The following is a description of a gene set: Furin is a proprotein convertase induced in activated T cells, reported to processes the anti-inflammatory cytokine TGFb-1. Herein, we show that conditional deletion of furin in T cells allowed for normal T cell development but impaired the function of regulatory T cells and effector cells, which produced less TGFb-1. Furin-deficient Treg cells, were less protective in a T cell transfer colitis model and failed to induce Foxp3 in normal T cells. Furin-deficient effector cells were inherently overly active and were resistant to suppressive activity of wild-type Tregs. Thus, our results indicate that furin is indispensable in maintaining peripheral tolerance, which is due, at least in part, to its nonredundant, essential function in regulating TGFb-1 production. Targeting furin has emerged as a strategy in malignant and infectious disease. The current work suggests that inhibiting furin might activate immune responses, but may result in a breakdown in peripheral tolerance. from publication Pesu M, Watford WT, Wei L, Xu L, Fuss I, Strober W, Andersson J, Shevach EM, Quezado M, Bouladoux N, Roebroek A, Belkaid Y, Creemers J, O'Shea JJ (PMID 18701887) Genes up-regulated in naïve wildtype CD4 T cells versus those from T cell specific FURIN knockout mice. Human Gene Set: GSE11884_WT_VS_FURIN_KO_NAIVE_CD4_TCELL_UP studied in species Homo sapiens, and this is the list of marker genes: PAXX, TM7SF3, FEZF2, GPR153, SRGAP1, RNF186, PDLIM2, MRM3, SNX18, DTHD1, IRF2BP2, PTGDR, RUSC2, KCTD12, TOMM34, LRRC30, CAVIN1, ASPH, PIR, ANKRD34B, RAB4B, MOXD1, SLC7A13, CATSPER1, MIR99B, GHRH, DSCC1, FLRT1, OTOG, SERPINB8, DAZAP2, NCKAP5L, RPS4Y2, SLC25A10, GALR2, SLC6A3 (solute carrier family 6 member 3), UNC45A, MARCHF8, GARNL3, PLIN1, PLCXD2, OMP, SH3PXD2A, DOK3, ZFP90, PM20D1, IFNA2, SHBG, DKKL1, SLCO4C1, HIP1, TBC1D9B, ANXA1, CCL1, SLC31A1, ODAD4, RPN1, PWWP3B, CCN2, PDGFRB, HTR5A, KLHL13, RIMKLA, ACAA2, CCDC107, CYBRD1, NUTM1, TCF7, GRK4, POM121L2, TAGAP, CLCN7, RNF152, TDRD12, MAB21L3, PRRG2, CD8B, CERS4, SMTNL1, ZBTB7C, OXTR, SSTR4, IFT22, NFKBID, NRCAM, FGFR1, CRIP2, MIR144, MTBP, WAS, XYLB, ALDH5A1, HEATR3, SELP, PILRA, EXT1, TJP2, CNN3, CCR8, MRPS31, PID1, CSNK1G2, ADAMTS4, GRIN2C, ANK1, LMOD3, SEZ6, MEPE, IL9, TYROBP, LPAR2, PRTN3, COPS5, ACKR1, MED10, FHAD1, WRAP73, DEUP1 (NCBI Gene Id 159989), SEC22B, MIGA2, PDIK1L, BAALC, CRYM, SNRPB, TARBP2, BMPR1A, RRAD, IFNLR1, LIPC, ZEB2, FXYD7, GGTA1, CCRL2, APOF, ARMCX6, ECH1, PTCD1, H1-9P, DAPL1, NDUFA10